Given this list of marker genes Optn, Irgm1, Tlr2, Rnf31, Tbk1, Nod1, Lrsam1, Irgm2, Ripk2, Mapk3, Nod2, Igtp, here is a description of the gene set: studied in species Mus musculus Mouse Gene Set: GOBP_REGULATION_OF_XENOPHAGY Any process that modulates the frequency, rate or extent of xenophagy.